The following is a description of a gene set: Any cellular process that stops, prevents, or reduces the frequency, rate or extent of the chemical reactions and pathways involving nucleobases, nucleosides, nucleotides and nucleic acids. Human Gene Set: GOBP_NEGATIVE_REGULATION_OF_NUCLEOBASE_CONTAINING_COMPOUND_METABOLIC_PROCESS studied in species Homo sapiens, and this is the list of marker genes: SFMBT1, SCAF4, WDTC1, GATA4, TRIB3, CELF4, MXI1, PHF24, ZBTB7A, RNPS1, PRDM8, NIF3L1, FASLG, SMARCE1, SCRT1 (scratch family transcriptional repressor 1), ID4, ALX1, BARD1, WWC3, CDA, SCGB1A1, ID2, RUNX3, FOXK1, TENT4A (NCBI Gene Id 11044), BEND3, PPARG, DNAJA3, TSHZ3, PURA, PAX2, MITF, ANXA4, CBX8, KDM5B, CDYL2, TAF7, FABP4, TRPS1, ZIC2, KLF3, SIN3B, MBTD1, PKIG, EZR, AMDHD2, MAF1, KAT2A, ZC3H8, HIF1AN, THAP5, DAB2IP, MAGEB3, PSMC5, RIOX2, FOXP1, CDKN1C, SIAH2, IRF8, KLF2, NFIC, SMO, LARP4B, NKX6-3 (NCBI Gene Id 157848), CREBRF, ZNF205, TENT5B, SETD5, EGR1, NR2C2, MAFG, DACT1, SMG6, PBXIP1, CXXC5, YBX3, URI1, PLCB1, PCBP4, ATF7IP, TWIST2, DUSP1, ZNF512B, NR3C1 (NCBI Gene Id 389335), ZNF397, DDX20, PPP1CA, TRAF2, FOXH1 (forkhead box H1), LBH, KEAP1, RRP8, HMGA1, RIPPLY3, MTA1, FAM220BP, AEBP1, CEBPA, FOXD3, GATA5, FNIP1 (folliculin interacting protein 1), ZSCAN4, CD36, BMP7, JAZF1, NR1I2, SFRP4, ACTRT1, HHEX, IREB2, PRAMEF4, SUV39H2, TBX22, MAGEA8, FOXO1, TGIF2, METTL14, IGF2BP1, HELT, FXR1, TFCP2L1, PTPRC, APBB1, CDK6 (cyclin dependent kinase 6), MAGEB16, ZBTB18, RARA, PER2, SLX1A, DCP2, WWC1, NDUFA13, SNCA (synuclein alpha), ZGPAT, FEZF1, FHL2, NKRF, PRMT5, LCOR, ZNF503, BMP2, HEYL, MTCH2, ZNF354C, STRAP, POU1F1, FOXA2, BLM, ARID5B, ENPP7, SP5, EHMT1, NR6A1, BCL11A, TLE1, GFI1, PHB1 (NCBI Gene Id 5245), CRY2, ZNF282, H1-1, IL33, HNRNPL, FAM76B, NRDE2, RNF169 (NCBI Gene Id 254225), MEIS2, SETDB2, EID2B, ID1, KDM1A, SUV39H1, VEGFA, SOX8, NEDD4, H1-9P, ZBTB1, FOXC2, KDM5C, ERN2, PFDN5 (NCBI Gene Id 5204), NFATC4, OLIG2, ZC3H14, FIS1, MYB, DEDD2, ZNF296, CGAS, ZNF174, BIN1, ZNF318 (zinc finger protein 318), MXD4, TCEAL7, SAP30L, IGF2BP3, PLK1, TBL1X, NR0B2, EXOSC10, TFAP2A, ELAVL4, MACROH2A1, ELK3, KAT5, HDAC7, EED, CDX4, VGLL4, XPO1, ZBTB42, ZNF675, GLIS2, PGK1, WWTR1, MAGEA10, PRAMEF5, WNT4, HBZ, PSEN1, HMBOX1, APOBEC3F, LIG3, PARP14, ZMYM5, HR, MYOZ1, TP53, PRAMEF26, SHLD1, L3MBTL4, PARN (poly(A)-specific ribonuclease), NRIP1 (NCBI Gene Id 8204), DNAJB4, MAGEC1, FBLL1, TRDMT1, KDM4A, VDR, HOXB8, CEBPD, NSUN2, SCML1, SUFU, H1-3, PKP1, RXRA, TINF2, BMAL1, MAGEB6, ZNF540, OSR2, ORC2, TP63, NOTCH2, SOX21, FOXP2, ZBTB26, FOXE1, GLIS3, TRAF5, NOSTRIN (NCBI Gene Id 115677), MBD3L2B, HNF1B, RCOR2, ZNF572, HEY1, BEND5, LMO4, MIR128-1, ZNF683, NKX2-5, ZBTB8A (zinc finger and BTB domain containing 8A), RUNX1T1, HNF4A (hepatocyte nuclear factor 4 alpha), PPARD, FLCN, LHX9 (NCBI Gene Id 56956), TCERG1, OTP, RBBP7, FOXF2, SQSTM1, CBX4, MYOZ2, ZBTB10, SALL1, SRSF10, COQ7, PRAMEF2, NUPR1, KLF11, RBM46, ANKRD1 (ankyrin repeat domain 1), MCPH1, PTCH1 (NCBI Gene Id 8015), MAGEE2, AMOT, CBX1, RCOR3, XCL1, ZC3H6, PER1, KCNIP3, SPI1, CRYAB, PKIA, PRDM12, NODAL, NPAT, TLE2, EFNA1, RYBP, ZNF281 (NCBI Gene Id 23528), LEFTY1, SAMD7, UBE2D1, BCOR, ZNF263, CDX2, NR0B1, DAZ2, PLA2G10, SCX, CDKN1A, ZBTB49, GDF2, PHC2, SRSF2, TIRAP, KAT2B, ZBTB7B, LDB1, CIRBP, CYREN, TCF21 (NCBI Gene Id 6943), SMARCA5, PARP3, BEND6, BIRC5, ZBTB37, PLAGL1, L3MBTL3, ZFPM1, PCGF2, OTUB1, UBQLN4, HDAC3, ABCE1, MTA3, ARK2N, NRG1, H3C15, ZNF827, NR2F6, MECP2, TENM2, ESR2, MAGEA6, CITED2, FOXG1, APOBEC3A, MOSPD1, ING4, SMAD4, NR1H2, CDC73, MMP12, ZFP92, ZNF418, ZNF658, CREM, HOXB4, ZMYND11, ATF3, TLE7, CSF2, WDR82, KMT5A, HIRA, ZMYM2, TRIM28, CIPC, TSPO, EPO, IRF7, MRE11, ZP3, CREB3L1, SAP30 (NCBI Gene Id 8819), MAGEC2, RSF1 (NCBI Gene Id 51773), SRSF9, CCND1, HOXD9, PRNP, HDAC8, ZBTB14, VIP, ZFPM2, MAGEB4, CIITA, HEY2, EREG, LMO1, GZF1, SHLD2 (shieldin complex subunit 2), BCL6, RALY, THRA, RAD17, PAX5, OLIG3, ZNF423, HOXA7, FOXJ1, CREBZF, NR2F1, FNIP2, PRDM14, SLC4A1, H3C14, MYF6, SMARCA4, CREBBP, MSX1, PARP10, PPP1R10, SMAD5, FST, BRD7, SIM2, KLF12, EDNRB, RBMX (RNA binding motif protein X-linked), LRRFIP1, TRIM11 (tripartite motif containing 11), ZNF24, CTC1, CELA1, HMX1, SDR16C5, NAB2, WNT10B, RPL23, N4BP2L2, NDN, ESRRA, HNRNPC, APOBEC3H, MIR221, MAX, PASD1, PER3, SOX12, RBM38, SENP3, ZNF639, NCOA5, PIF1, SIK1, TBL1XR1, MXD1 (NCBI Gene Id 4084), NR4A2, TEN1, SAP18, NR1D2, ZNF559-ZNF177, EZH2, PHF12, LIN37, NELFA, MNX1, MBD3, GZMA, MORC1, ZNF134, ETV5, MNT, STRN3, SRSF1, SOX4, TRIM33, CDKN2A, RD3, LIMD1, TNKS2, PRAMEF14, TAF3, PCNA, DMBX1, FBXO5, H1-6, THAP11, PDS5A, HDGF, FBH1, WNT5A, MLH1, SKOR1, ESX1, L3MBTL2, H1-7, PA2G4, PURB, FGF9, TFEC (transcription factor EC), H1-2, PEX14, ZBTB4, RNH1, MAGEA3, DAXX, ELANE, NPM1, ZBTB20, ZKSCAN3, DCAF1, PRAMEF12, PHF19, TCF3, PRAMEF10, PML, ADIPOQ, MLIP (muscular LMNA interacting protein), PAIP1, SMAD3, HES7 (hes family bHLH transcription factor 7), ZNF253, WWC2, DHX36, ANKLE1, TAF15 (NCBI Gene Id 8148), ENO1, OVOL2, PPP2CA, ZNHIT1, ERF, APOBEC1, FCN3, DKK1, SFRP2, IFNL1, HNRNPA0, MTERF3, TFDP2, MAGEB10, HSF4, MAFK, SUDS3, HOXA2, PHAX, SECISBP2, FOXA1, GMNN, RPS3, PEG3, TMBIM6, ATXN1, MAGEA9, HSPA8, NKX6-1, IRF2, PKP3, U2AF2, GAS6, RPS6KA5, MZF1, NOCT, GATA6, FOXC1, DDIT3, CBX6, ZEB2, PTPN2, MAGED4, GCLC, LEF1, CTNND1, OSR1, DNMT1, MEF2A, ZNF536, NOTCH3, NFATC2, SOX3, TNKS, RBM10, EIF4ENIF1, ZBTB38, SAP130, IRX2, MAGEB17, GATAD2A, RN7SK, HES6, ZNF425, RBAK, EN2, CIR1, PRDM11, C1QBP, DYRK1A, ACIN1 (apoptotic chromatin condensation inducer 1), JARID2, PIAS4, TNFSF11, ZNF217, STAT3, CBX3, TDG, TRIB1, ATN1, ZNF219, SFN, PRDM1, QARS1, RERE, UIMC1, SOX7, MAGEA1, ZNF354B, NSD2, NFIB, PRAMEF33, SMTNL1, CDT1, PRAMEF11 (PRAME family member 11), TCF7L2, MIR675, HDAC6, BAHD1, CDY2B, ELAVL1, SLX1B, SNAI2, FLNA (NCBI Gene Id 8272), SIRT6, NONO, BMP4, RBM15B, SMAD7, BACH2, SOX2, BCORL1, GABPA, OTUD7B, IRX1, SIRT2, HSF1, ZBTB12, AEBP2, EID2 (EP300 interacting inhibitor of differentiation 2), CC2D1A, INPP5K, LARP1B, KHDRBS1, VAX1, SLX4, HES1, NOP53, H1-5 (NCBI Gene Id 3009), CREG1, NR2E1, ZNF268, HAND1, SRC, COPS2, TBL1Y, GNL3L, XRCC5, DAZ3, ANKRD2, ZNF431 (zinc finger protein 431), APOBEC3C, TBX20, POU4F1, PRAME (NCBI Gene Id 4136), UXT, TXNIP (NCBI Gene Id 10628), HDAC4, IRF1, PSMD10, SATB2, TGFB1, TRIM6 (NCBI Gene Id 117854), SREBF2, DDIT4, NKX3-2, ZHX2, SIX3, YWHAQ, PAF1, POU3F3, PTPRK, NR1I3, SOX1, SARS1, PRAMEF17, ZNF202, MAP3K10, NBAS, E2F7, TRPV1, NR1D1, PDX1, NCOR2, MAGEB2, MIER3, PRDM6, KDM8, PRMT2, AURKB, MSC, GADD45A, CC2D1B, ZFTA, SPDEF, PPARA, ZNF12, UHRF1, NFIX, MSX2, ZNF589, ZNF608, SRF, PRICKLE1, TNF, WWP2, ZC3H4, SORBS3 (sorbin and SH3 domain containing 3), XRCC6, E2F1, NICOL1, HIPK2, NELFE, AR (NCBI Gene Id 367), DDX21, PPM1F, DKC1, HNRNPAB, ZNF488, NOG, TFAP2B, PRDM16, SP2, ZNF131, CALCA, NOC2L, NUPR2, TLE4, SOX11, DLX2, MYPOP, SUMO4, TRPV4, ZBED6, MAGEB18, ENG, DLG1, HCRT, QKI, TAF9B, ZBTB5, CSDE1, TOB2, RIPPLY2, ING2, HIVEP1 (NCBI Gene Id 3096), BAZ2A, ZMYND15, PRAMEF8, RFC1, SMURF2, ZBTB25, CALR, SIX5, BCL6B, RBBP4, TXN, ZBTB17, ZBTB6, PHC3, ZBTB34, PHB2, YY1, HES5, KAT8, CNOT2, SKIL, FRK, E2F8, USP2, PAX6, ZAR1, ATP5IF1, FOXM1, HMGB1, GIT1, ZNF469, WFS1, TCF7, METTL1, ELF2, POLE3, HCFC2, FOXS1, KDM2B, IGF2, TRIM63, SFPQ, ZBTB39, DUSP15, BHLHE41, A1CF, HES2, ERCC1, ZNF177, MAGEA2B, L3MBTL1, JPH2, MAGEA2, NELFB, NFIL3, ZNF148, PRAMEF20, BCL3, INSM1, FOXQ1, ZNF133, TRAF3IP2, NCOA2, AASS, SNX6, MDM4, TLE3, TLE5, TBX18, IMPACT, MAZ, MACROH2A2, PIAS3, TCFL5, RADX, HEXIM2, FGFR2, E2F6, RTEL1, MAGEB5, SOX9, BAG4, CAMSAP3, BTRC, SOX30, NIPBL, HIF1A (hypoxia inducible factor 1 subunit alpha), ZBTB2, AMOTL2, RBM20, SOX10, RNF2, EDN1, PHF21A (PHD finger protein 21A), GSTP1, SHOX2, CUX2, ATM, CEBPB, DNMT3A, MSH2, MDFIC2, CTBP1, NDFIP1 (Nedd4 family interacting protein 1), HELB, PDCD4, CIC, PCGF6, RREB1, WT1, FOXL2, C1D, CDY2A, INSM2, CLOCK, ZNF345, SGF29, XBP1, DNAJB5, SRSF4, IKBKE, MLXIPL, SLFN11, TRIM37, PAWR, EAPP, TERF2IP, ATP8B1, ARX, ZNF175, ZBED2, CDKN1B, GATAD2B, DEAF1, PARP15, DACH1, PHF6, SATB1, PRAMEF6, APOBEC3B, HMGB2, CBY1 (NCBI Gene Id 25776), PABPC1, TAL1, ELK4, NR4A3, PPM1A, RUVBL2, HNRNPD (heterogeneous nuclear ribonucleoprotein D), DDX5, CNBP, SUPT4H1, HNRNPK, CBFA2T3, RING1, ZNF541, MED25, THAP7 (THAP domain containing 7), GATA3, PTBP1, AHR, HIC2, PROX1, ZNF274, MDFI, TENT5A, LOXL3, IRX4, PRAMEF27, SNAI1, ZHX1, PRAMEF19, DNAJC17, SUZ12, MTA2, SLIRP, PDE2A (NCBI Gene Id 5138), FZD6, TNFSF4, BTAF1, VHL, MBD2, SMCHD1, NPPC, CASP8AP2, HMGA2, DPF2, OGG1, SP3, ARID5A, TRIM22, BRMS1, MAGEE1, CBX7, MTDH, MBD1, YEATS2, NUDT16, CCAR2, DFFA, TBX3, CHD8, SF1, CAPN3, CTBP2, HINFP, HOXC8, TERF1, SREBF1, S100A11, NOTCH4, TENT5D, ZNF239, BATF3, ETS2, NCK1, YWHAB, MYD88, TBX21, CTNNB1, NCOR1, NACA, CCAR1, DHX9 (DExH-box helicase 9), DMAP1, ZNF750, DKK3, SBNO2, GDNF, CENPF, SMAD2, MAPKAPK2, HOXB13, HEXIM1, XRCC1, PSPC1, ASCL2, ZNF668, RECQL5, H1-0, ACD, MEPCE, KAT6A, LIMS1, SCMH1, RPL10, KLF5, BAP1, DAB2, ASCL3, ZBTB32, SPINDOC, PIAS1, RMI2, GATA1, NFKBIA, DND1, PRRX1, DRAP1, PRAMEF1, KLF4, KCNK2, AICDA, DUSP26, ETV6, NFKB1, TFAP2C, FEZF2, KDM2A, CD38, ACTR6, FOXP3, CITED1 (Cbp/p300 interacting transactivator with Glu/Asp rich carboxy-terminal domain 1), TSG101, ZNF136, HSBP1L1, RIOX1, ZFP90, IRF2BP2, IL4, PRAMEF7, MAGEH1 (MAGE family member H1, NCBI Gene Id 94692), IGBP1, PHF14, PARPBP, H1-10, RCOR1, EID1, TRIM24, MYOCD, MUC1, SALL4, MIDEAS, DLL4, KLF7, JDP2, CGGBP1, BPTF, BHLHE40, MAGED4B, HOXB3, BCL7A, TNP1, IRX3, CHD4, MAGEA11, CBFA2T2, CSNK2A1, NAB1, LARP7, RBL1, RASD1, THRB, CDY1, RBM42, RBFOX2, ZNF93, MECOM, PAX9, NR1H3, IKZF1, CUL3, ISL1, BRCA1, HESX1, IKZF4, NFE2L3, SRSF7, NR1H4, TRO, NOTCH1, HSBP1, DNAJB6, E4F1, NFATC3, ZSCAN10, FBLN5, DDX54, NKX6-2, LOXL2, AUNIP, HOPX, RARB, CRY1, PRDM5, PRAMEF13, ZBTB46, DMRT1, MORC3, GSC, LEP, KLF8, KAT14, PRAMEF22, HOXD8, CCND3, BMP6, ZBTB21 (zinc finger and BTB domain containing 21), ZNF350, IRF3, OGT, ILF3, DLX4, PRAMEF18, TP53BP1, GATA2, HDAC5, CCNE1, FOSB, FUS, ZNF8 (NCBI Gene Id 7554), ERCC6, ZNF304, TERF2, MYT1L, ACE2, POLQ, ACTN3, TSC22D4 (TSC22 domain family member 4), MBD3L3, TTF1, OVOL1, WAPL, RELA, TCF23, NMNAT1, PPP1R13L, FOXR1, LANCL2, IRF2BPL, H1-8, TPR, IFI16, MBD3L5, NCK2, STN1, NEUROG3, NKAP, SINHCAF, PFKFB1, FOXO3, KDM5A, RBBP8, YAF2, MCRS1, ZNF777, DLX1, ZNF438, FGFR1, ACVR2B, TRAF6, STAT6, POU5F1, GTF2IRD1, MAGEB1, POT1, DAZ1, FANCB, APEX1, IRF2BP1, PDGFB, MESP1, HIC1, TBX6, DYNLL1, VAX2, TFAP4, EHMT2, ZNF396, MEN1, CDK5, YWHAZ, CTCF, LMCD1, SCML2 (NCBI Gene Id 10389, Scm polycomb group protein like 2), LYAR, TRERF1, RNF168, ZNF254, DAZ4, PROP1, ELF3, PRDX5, SLA2, MBD3L4, NR2E3, AXIN1, FOXN3, NFE2L1, USP9X, TRIM29, SMYD2, TADA3, MAGEA4, MAGEA12, DNMT3B, ZBTB16, FERD3L, CDC6, GLIS1, CBFB, DNAJB1, ATF2, FOXK2, MYC, SUMO1, TENT5C, HNRNPA1, SOX15, TRIM27, ESR1, SHLD3, TBX15, TARDBP, BTG2, ZNF140, HCLS1, HMG20A, SCAF8, ID3, MED1, SSX1, HDAC1, RARG, NSMCE3, ATXN1L, ZHX3, MAGED1, BACH1, CUX1, SRSF12, BMI1, HAMP, SET, PRKACA, CNOT7, CBX2, KCTD1 (NCBI Gene Id 284252), MAGEA13P, WTIP, PARP1, DEPDC1, SUPT5H, HJV, AXIN2, SMARCC2, NAT10, DFFB, CHD3, APBB2, RIF1, NUDT16L1, POU4F2, ZGLP1, EN1, RTF1, H1-4, GTPBP4, IER3, MAF (NCBI Gene Id 4094), NRARP, HDAC2, MSH3, SFMBT2, TSPYL2, IKZF5, SRSF6, ZNF224, GMPPA, MAGED2, FZD1, HDAC9, ARID4A, RFX3, NSD1, PRDM2, NAF1, CBX5, ABL1, ZEB1, NR2F2, ZC3H12A, RITA1, TIMELESS, FLYWCH1, TNFRSF4, APOBEC3G, TAGLN3, IFNG, MAGEA9B, MIER2 (MIER family member 2), PHC1, HNRNPU, ETV7, PCBP3, SHC1, ZFHX3 (NCBI Gene Id 463), ANGEL2, NRIP2, RBM15, RB1, CDYL, TENT2, TCP10L, TLE6 (NCBI Gene Id 84846), TBX2, NACC2, SHH (sonic hedgehog signaling molecule), THRAP3, ZNF85, GLI3, SYNCRIP, GLI2, SPEN, S100A1, APOBEC3D, JUN, MDFIC, LDB2, AJUBA, RUNX2, NKX3-1, GPS2, ZCCHC17, PITX2, FOXD1, POU6F1 (NCBI Gene Id 5463), ZNF746, DNAJC2, TENT4B, ASCL1, SIRT1, RLIM, DEDD, MAP2K5, REST, KLF10, SIN3A, NBN, SOX18, HDAC10, CPEB3, TGIF2LX, TIGAR, RORB, FOXF1, ETV3, TMPRSS6, GSK3A, TGIF2LY (TGFB induced factor homeobox 2 like Y-linked), ZFP36, ARID4B, PINX1, MAGEC3, ZBTB45, PRAMEF15, MXD3, RFX5, ZNF256, MEF2C, YAP1, BARX2, SIX1, SOX14, DICER1 (dicer 1, ribonuclease III), PLK3, PATZ1, PRAMEF25 (NCBI Gene Id 441873), MAPK14 (NCBI Gene Id 1432), NIBAN2, TWIST1, COMMD7, RELB, JUND, ZNF703, EPC1, NFX1, FAM220A, NELFCD, SFSWAP, PARP9 (poly(ADP-ribose) polymerase family member 9), LHX1 (NCBI Gene Id 3975), PPHLN1, SCML4, GREM1, KLF16, ZNF653, CDK5R1, APP, ATF5 (NCBI Gene Id 22809), MBD3L1, ATOH8, ATR, PWP1, LILRB4, ING1, HCFC1, EP300, METTL16, HSPA1A, MAD2L2, NKX2-1, FOXP4, SAMD1, PPID, TFIP11, UPF3A, VPS72, CDY1B, CCDC85B, TDP2, NPAS1, MAFF, SFRP1, MAFB, MAGEB6B, ALDOB, XRN1, MBD3L2, PCGF1, TGIF1, WWP1 (NCBI Gene Id 81891), TBXT, MAEL, ZNF706, IFI27, TOB1, IFNA2, IGF2BP2, DR1, NANOG, GFI1B (growth factor independent 1B transcriptional repressor), SUB1, PRKN, SDCBP, SLC11A1, ERCC4, CNOT1, NEIL1, YBX1, KCTD15, UBE2D3, ATF4, DUSP22, SNAI3, ASAH1, WDR5, ZNF568, RNF8, ZNF451, ATF7, ZNF91, VSX2, TET1, MIER1, PITX1 (paired like homeodomain 1), ZMYND8, SIX4, EZH1, NACC1, RORC, RPS14, CRYM (NCBI Gene Id 1428), SCRT2, SP100, SKI, PRMT6, ZNF141, RUNX1, SNW1, MAGEL2, THAP1, TIPIN, KLHL15 (kelch like family member 15), BCLAF1, DHX34, MBIP, UBE2I, BRMS1L, STAT1, RAD50, PRDM13 (PR/SET domain 13, NCBI Gene Id 59336), SCAI, MAGEF1, MSH6, SOX13, ZBTB33, CAV1, TBR1, TAF1, CTNNBIP1, CREB1, POU2F1, HSF5, ZNF366, BASP1, RBM24, RBM47, MYBBP1A, SOX6, PID1, DAZL, ZNF692, PRAMEF9, H3C13, EOMES, MEIOC, KANK2, RIPPLY1, RBPJ, SMARCA2, SEMA4D, LRPPRC, SMYD1, NR2C1, LARP1, SKOR2, MDM2, KAT6B, SAMD11, FBP1, MLX, CDK2 (cyclin dependent kinase 2), CIART, CTR9, DNMT3L, BOLL (boule homolog, RNA binding protein), SARNP, SIRT7